The following is a description of a gene set: Human Gene Set: RAFFEL_VEGFA_TARGETS_UP The infant leukemia-associated gene Ott1 (Rbm15) has broad regulatory effects within murine hematopoiesis. However, germ line Ott1 deletion results in fetal demise prior to embryonic day 10.5, indicating additional developmental requirements for Ott1. The spen gene family, to which Ott1 belongs, has a transcriptional activation/repression domain and RNA recognition motifs and has a significant role in the development of the head and thorax in Drosophila melanogaster. Early Ott1-deficient embryos show growth retardation and incomplete closure of the notochord. Further analysis demonstrated placental defects in the spongiotrophoblast and syncytiotrophoblast layers, resulting in an arrest of vascular branching morphogenesis. The rescue of the placental defect using a conditional allele with a trophoblast-sparing cre transgene allowed embryos to form a normal placenta and survive gestation. This outcome showed that the process of vascular branching morphogenesis in Ott1-deficient animals was regulated by the trophoblast compartment rather than the fetal vasculature. Mice surviving to term manifested hyposplenia and abnormal cardiac development. Analysis of global gene expression of Ott1-deficient embryonic hearts showed an enrichment of hypoxia-related genes and a significant alteration of several candidate genes critical for cardiac development. Thus, Ott1-dependent pathways, in addition to being implicated in leukemogenesis, may also be important for the pathogenesis of placental insufficiency and cardiac malformations. species: Mus musculus from publication Raffel GD, Chu GC, Jesneck JL, Cullen DE, Bronson RT, Bernard OA, Gilliland DG (PMID 18981216) Genes up-regulated in hearts of E18.5 embryos upon knockout of VEGFA., and this is the list of marker genes: ACVR2B, E2F3, SOX11, GNB1L, HIF1A, PBX1, CITED2, WT1, HEY2